The following is a description of a gene set: Mouse Gene Set: GOBP_POSITIVE_REGULATION_OF_D_GLUCOSE_TRANSMEMBRANE_TRANSPORT Any process that increases the frequency, rate or extent of glucose transport across a membrane. Glucose transport is the directed movement of the hexose monosaccharide glucose into, out of or within a cell, or between cells, by means of some agent such as a transporter or pore. studied in species Mus musculus, and this is the list of marker genes: Braf, Erfe, Pou4f2, Rasa1, Itln1 (NCBI Gene Id 640587), Smim43, Mfn2, Clip3, Erbb3 (NCBI Gene Id 97627), Klf15, Met, Nr4a3, Mef2a, Oga, Opn3, Gpc3, Irs2, Ins1, Akt2, Fgf21, C1qtnf12, Ptpn11, Rnasel, C1qtnf2 (NCBI Gene Id 69183), Appl1, Aoc3, Capn10, Pth, Irs1, Insr, Erbb4, Ocln, Nfe2l2, Adipoq, Igf1, Mapk14, Adipor2, Prkcd, Ak1, Gip, Osbpl8, C2cd5, Fgf15, Slc1a2, Crebl2, Akt1, Gh, Tert, Rhoq, Repin1, C3, Rap1a, Ins2, Prkci, Sorbs1